Given this list of marker genes Ppa2, Ppa1, Lhpp (NCBI Gene Id 76429), here is a description of the gene set: electronically inferred by orthology from the curated human pathway part of: Metabolism Reactome Pathway: Pyrophosphate hydrolysis studied in species Mus musculus This event has been computationally inferred from an event that has been demonstrated in another species.<p>The inference is based on the homology mapping from PANTHER. Briefly, reactions for which all involved PhysicalEntities (in input, output and catalyst) have a mapped orthologue/paralogue (for complexes at least 75% of components must have a mapping) are inferred to the other species.